The following is a description of a gene set: A process in which a protein is transported to, or maintained in, a location within an endosome. studied in species Mus musculus Mouse Gene Set: GOBP_PROTEIN_LOCALIZATION_TO_ENDOSOME, and this is the list of marker genes: Zdhhc1, Vegfa, Washc2, Arl8b, Mgat3, Rcsd1, Rab35, Rdx, Sorl1, Dtx3l, Nrp1, Tmem30a, Arf6, Nf2, Egfr, Pacsin2, Abhd17c, Vps35, Ezr, Msn, Akap11, Ankrd13a, Tollip, Rock2, Grin2a (NCBI Gene Id 14811), Abhd17a, Egf, Abhd17b, Micall1